The following is a description of a gene set: mouse primary BMDCs were stimulated with tlr ligands and gene expression changes were profiled on Affymetrix arrays from publication Amit I, Garber M, Chevrier N, Leite AP, Donner Y, Eisenhaure T, Guttman M, Grenier JK, Li W, Zuk O, Schubert LA, Birditt B, Shay T, Goren A, Zhang X, Smith Z, Deering R, McDonald RC, Cabili M, Bernstein BE, Rinn JL, Meissner A, Root DE, Hacohen N, Regev A (PMID 19729616) Genes up-regulated in comparison of control dendritic cells (DC) at 24 h versus those stimulated with LPS (TLR4 agonist) at 24 h. Human Gene Set: GSE17721_CTRL_VS_LPS_24H_BMDC_UP species: Homo sapiens, and this is the list of marker genes: GPR146, GUSB, FAM111A, S100A9, MICOS10, PPP4R1, DAG1, PLD1, SPTLC1, NEK7, KLK6, ANXA1, KLF5, MFSD5, SMPD2, IL18, SASH3, MGAT2, QDPR, MFHAS1, GALK2, CPT1A, MEIS3, IQGAP3, GPX3, MRPS15, NRROS, USP42, SLC30A5, STEAP1, HAUS4, SV2A, NSMF, PITX1, ADCY7, RNF7, PCBP2, XPC, SOCS6, IMP3, CD93, CCNG1, EIF3L, UBR1, IFT80, ARID1A, SMPDL3A, SLC7A7, WDR12, RGL2, LGALS8, LPGAT1, HOXA5, RETREG2, FASN, ZNF124, SYNPO, NFAM1, CDKN2C, POLG, CX3CR1, TOPBP1, TEX12, CLNK, DMAC1, LTBP3, ASCC1, GNPDA1, SIDT2, GALNT2, ELAC1, CENPF, HAUS8, CTNNA1, XPNPEP2, PDLIM2, HPGDS, GLCCI1, NLGN1 (NCBI Gene Id 22871), RP9, TRIM11, COL4A5, ARRB1, KIF20A, XPR1, CLINT1, NECAP1, GMPR, LIMA1, DOK3, ZNF189, LRRTM2, DGAT1, SVIL, CASP6, TESK2, MYO5A, MACROD1, ASB5, ELOVL7, MLLT10, NCOA1, RGL3, PTPRZ1, TPRN, NIPAL2, SERPINA10, INSR, TSPAN5, PRKAG1, RPL6, ABCG2, TCN2, ELMO2, EEPD1 (endonuclease/exonuclease/phosphatase family domain containing 1), FAM98C, CPA3, EPS15, OTULIN, RASSF3, TLE2, NPR1, MCM7, SMC2, RANBP10, SPECC1, HABP4, AIMP1, MARVELD2, PDCD1, NR1D2, RAMP1, LCMT1, CAPZA2, LIMD2, PLXNB2, CACFD1, RPS6, PHOX2B, NEPRO, MYCL, CRISPLD1, MYO1E, RAC1, C1QBP, ANLN, PBX2, TNNT1, ACRBP, CD177, DDX3X, RNF181, HLA-DMA, CASD1, CAPN15, CUTA, KHK, CIDEB, CLCN6, BCL2L11, PEPD, USP27X, BCL7C, PDXK, PAG1, VIPAS39, WWC2, LYSMD2, SSBP2, SLC12A5, DBH, EML5, SMARCD1, PALD1, CAPZA1, FKBP1B, PTPRO, MED22, HHEX, RND3, CPB2, MCM3, ERCC6L, MRPL36, ABCB7, MAPK3, EIF3H, DLX2, SPG21, RPL31, CDADC1, FOXI1, TFEC, BPHL, CORO1A, GAK, SESN1, RPL30, PADI3